Given this list of marker genes Pde4b, Dmxl1, Nemp1, Tsr2, Ino80d, Asic3, Peg3 (paternally expressed 3), Gnal, Kcnip3, Mlip, Coro2b, Mlec, Samd4b, Nek5, Naip1, Tbc1d19 (TBC1 domain family, member 19), Cphx1, Tmem243, Rfx7, Dexi, Arhgef12, Ube3c, Heyl, Mixl1, Plagl1, Mecp2, Nedd1, Brd10, Vamp3, Pnma2, Tom1l2, Luc7l3, Vgll1, Mmp2, Cbx5, Sele, Eif4e2, Lzts3, Taok3, Trib2, Skint9, Fbxl17, Pbx2, Commd2, Azin1, Pip4p1, Ppp2r2b, Ptpn5, Elf4, Aak1, Acvr2b, Arid1a, Arid3b, Arhgap15, Slc50a1, Thap2, Atp2a1, Gpr61, Ccdc96, Ppp1r3g, Tspan13, Il1rl1, Maz, Bgn, Xpo7, Oxt, Agap2, Cul3, Wnt9b, Pecam1, Phf8, Cwf19l1, Cacna1i, Zfp36l1, Zfp609, Slc8a3, Tmem94, 1700017B05Rik, Tex261 (testis expressed gene 261), Dhdh, Lce1a1, Rnps1, Chd2, Wfdc1, Lad1, Zmym2, Six1, Vps4a, here is a description of the gene set: Genes predicted to be targets of miRBase v22 microRNA mmu_miR_3572_5p in miRDB v6.0 with MirTarget v4 prediction scores > 80 (high confidence targets). species: Mus musculus Mouse Gene Set: MIR_3572_5P from publication Chen Y, Wang X (PMID 31504780)